The following is a description of a gene set: Genes predicted to be targets of miRBase v22 microRNA mmu_miR_6944_5p in miRDB v6.0 with MirTarget v4 prediction scores > 80 (high confidence targets). studied in species Mus musculus Mouse Gene Set: MIR_6944_5P from publication Chen Y, Wang X (PMID 31504780), and this is the list of marker genes: Kbtbd3, Slc25a34, Zdbf2, Scgb1b2, Pptc7, Tmx4, Gpr149, Cers3, Arhgap31, Rgs9, Tpbpa, Nop58, Gpd2, Gm5591, Ppp1r17, Ammecr1l, Phkg1, Gpr61, Zhx1 (zinc fingers and homeoboxes 1), Crppa, Ptk7, Gjd4, Slc22a8, A930018P22Rik, Stx8, Mapk8ip3, Tm4sf5, Tgfb1i1, Pacs2, Zfp532, Ppa1, Camsap2, Smarce1, Saysd1, Tnfrsf21, Ssh2, Fbxo48, Hdac8, Fabp12, Msx1, Tyw3, Gpd1, Bcs1l, Scai, Vmn2r43, Sumo2, Mtcl2, Ikzf3, Mtm1, Esp36, Klhl29, Gucy1a2 (NCBI Gene Id 70710), Azi2, Tbx6, Rarb, Ehbp1l1, Dcx, Casd1